Given this list of marker genes PTPMT1, DKC1, EBNA1BP2, PSMD8, AASDHPPT, CDK1, TENT2 (terminal nucleotidyltransferase 2), FIBP, TYMS, IP6K2, NMT1, GPR89B, NOMO3, LSM4, EZH2, NUDT5, CYP2R1, LSM5, MRPL43, RAN, AIMP2, UTP4, SSBP1, CDC23, CEP152, IARS1, EMC4, KEAP1, MCM2, CCT5, NASP, FAM98B, G3BP1, IK, EDRF1, PAAF1, C1orf131, CHCHD1, EIF3G, ZNG1A, ZNF367, KLF13, TEFM (NCBI Gene Id 79736), THYN1, TMEM165, LAP3, C1QBP, RNF7, DDX1, HAUS1, PRKDC, CCT2, RACGAP1, IREB2, NUDCD2, TBCB, CMC1, CHMP4A, TMEM126A, TIMM50, CHEK1, SLC38A1, NCAPD3, RFX7, MALSU1, BARD1, MRPS12, NDUFA13, SGO2, RPL26L1, CEP295, ASF1A, EFTUD2, PPP1R12A, SLC16A1, TDP2, here is a description of the gene set: Human Gene Set: MOREAUX_B_LYMPHOCYTE_MATURATION_BY_TACI_DN Genes down-regulated in normal bone marrow plasma cells (BMPC) compared to polyclonal plasmablasts (PPC) that also distinguished multiple myeloma (MM) samples by expression of levels of TACI. species: Homo sapiens B-cell activating factor (BAFF) and a proliferation-inducing ligand (APRIL) have been shown to promote multiple myeloma (MM) cell growth. We show that the main site of production for BAFF and APRIL is the bone marrow (BM) environment, and that production is mainly by monocytes and neutrophils. In addition, osteoclasts produce very high levels of APRIL, unlike BM stromal cells. Myeloma cells (MMCs) express TACI (transmembrane activator and calcium modulator and cyclophilin ligand interactor), the receptor of BAFF/APRIL, at varying levels. TACI expression is a good indicator of a BAFF-binding receptor. Expression data of purified MMCs from 65 newly diagnosed patients have been generated using Affymetrix microarrays and were analyzed by supervised clustering of groups with higher (TACI(hi)) versus lower (TACI(lo)) TACI expression levels. Patients in the TACI(lo) group had clinical parameters associated with bad prognosis. A set of genes was differentially expressed between TACI(hi) and TACI(lo) MMCs. This set makes it possible to efficiently classify TACI(hi) and TACI(lo) MMCs in an independent cohort of 40 patients. TACI(hi) MMCs displayed a mature plasma cell gene signature, indicating dependence on the BM environment. In contrast, the TACI(lo) group had a gene signature of plasmablasts, suggesting an attenuated dependence on the BM environment. Taken together, our findings suggest using gene expression profiling to identify the group of patients who might benefit most from treatment with BAFF/APRIL inhibitors. from publication Moreaux J, Cremer FW, Reme T, Raab M, Mahtouk K, Kaukel P, Pantesco V, De Vos J, Jourdan E, Jauch A, Legouffe E, Moos M, Fiol G, Goldschmidt H, Rossi JF, Hose D, Klein B (PMID 15827134)